Given this list of marker genes ING2 (inhibitor of growth family member 2), HOPX, MAPK8, SIRT6, UCN, TP53, SKI (SKI proto-oncogene), here is a description of the gene set: Human Gene Set: GOMF_HISTONE_DEACETYLASE_REGULATOR_ACTIVITY Binds to and modulates the activity of histone deacetylase. studied in species Homo sapiens